The following is a description of a gene set: Human Gene Set: HP_FINGER_APLASIA Finger aplasia studied in species Homo sapiens A developmental defect resulting in the presence of fewer than the normal number of fingers (i.e., aplasia of one or more fingers)., and this is the list of marker genes: BHLHA9 (NCBI Gene Id 730701), MEGF8, SLX4, TUBB2B, TBX5, COL25A1, RPL35A, NIPBL, PALB2, RSPO2, TP63, GATA1, RPS19, RBM8A, IFT140, RPL18, BMPR1B, RIPK4 (receptor interacting serine/threonine kinase 4), TBX3, TSR2, RPS15A, FANCB, DONSON, LMBR1, FANCI, LMNA, FBXW4, FIG4, SHH, RPL5, DLX6, FANCE, RPS29, FANCL, FGF10, XRCC2, ESCO2, PORCN, DLX5, ERCC4, RPS10, RPS27, ATP6V1B2, SMOC1 (NCBI Gene Id 64093), RPL9, EN1, TUBB3 (NCBI Gene Id 94749), SALL4, CHD7, SEM1, SON, RECQL4, GJA1, RPS17 (ribosomal protein S17), RPL31, FANCA, RPL35, TRIO, KIF21A, PSMD12, RPS24, RPL11, RPS26, CUL3, ERI1 (exoribonuclease 1), RPS28, WNT10B, FANCD2, RFWD3, PHOX2A, SF3B4, HEATR3, FGFR2 (NCBI Gene Id 2263), FANCF, ADA2, RAD51C, RPL27, WNT7A, RPS20, TUBA1A, VAC14, NEK1, BTRC, RPL26, RPS7, RPL8, NSDHL, FANCC, FGFR3, EPS15L1, RAD51, RPL15